The following is a description of a gene set: from publication Zheng S, Papalexi E, Butler A, Stephenson W, Satija R (PMID 29545397) Human Gene Set: ZHENG_CORD_BLOOD_C7_PUTATIVE_LYMPHOID_PRIMED_MULTIPOTENT_PROGENITOR_1 studied in species Homo sapiens, and this is the list of marker genes: SMIM24, STARD4-AS1, SPINK2 (serine peptidase inhibitor Kazal type 2), MALAT1, C6orf62, XIST, SNHG29, ZC3HAV1, ARID4A, SLK, PIM2, CYTIP, PABPC1, VPS35, LRRC75A, USP36, EIF2S3, PSMA6, TCERG1, TPM4, RILPL2, ZBTB8A, TPT1, TTC3, ENO1, ANKRD36C, ANKRD28, WDR49, MSI2, RPL30-AS1, HSPA5, FLT3, IFITM3, TUBA1B, CSGALNACT2, C1QTNF4, KRAS, HIF1A, IFNGR1, MZB1, TRIM24, MAP3K8, BTF3, TTF1, MT-ATP8, MT-RNR2, CALR, ANKRD26, BCL7A, CCDC14, PIK3R1, MIS18BP1, CSF3R, NAP1L1, PTPRE, TSIX, LRRFIP1, GYPC, CHD1, SPN, RUNX1, ATG10 (autophagy related 10), KPNB1, CASP4, RFLNB, GBP4, NPDC1, GNB4, CD99, SET, DYNLT1, DEK, BEST1, FAM161A, GTF3A, MT-ND6, ZRANB2, BCL11A, SPTBN1, ZFP36L2, CALCOCO2, HSP90B1, IFI16, MT-ND5, KRR1, MACROH2A1, BRCA2 (NCBI Gene Id 82716), SELL, ANKRD36, TAOK3, IFITM1, GLIPR1, NUCB2, SFXN1, TCF7L2, HNRNPH1